Given this list of marker genes Ecrg4, Crh, Ucn, Crhr1, Aqp1, Lif, Rab8b (NCBI Gene Id 235442), Pex5l, Crhbp, Apln, Ghrl (NCBI Gene Id 80454), here is a description of the gene set: The regulated release of corticotropin by a cell. Corticotropin hormone is a polypeptide hormone synthesized and secreted from corticotropes in the anterior lobe of the pituitary gland in response to corticotropin-releasing hormone (CRH) released by the hypothalamus. Mouse Gene Set: GOBP_CORTICOTROPIN_SECRETION studied in species Mus musculus